Given this list of marker genes SEPSECS, TSFM, MT-CO3, POLG, SLC25A20, AMPD1, TSEN34, SLC25A42, TSEN15, CACNA1S, ALDOA, PGK1, BCS1L, LDHA, SLC12A3, MLIP, TRAPPC2L, SUCLG1, CPT2, CTDP1, ANO5, TNNT1, ISCU, CLCNKB, PGM1, KCNJ18, PHKB, GABRA3, DGUOK, PYGM, HADHB, OBSCN, TSEN2, FDX2, RYR1, LPIN1, TSEN54, ACADVL, ATP5F1D, MT-CO1, PGAM2, XK, HADHA, AMACR, TANGO2, here is a description of the gene set: Breakdown of muscle fibers that leads to the release of muscle fiber contents (myoglobin) into the bloodstream. Human Gene Set: HP_RHABDOMYOLYSIS Rhabdomyolysis studied in species Homo sapiens